The following is a description of a gene set: studied in species Homo sapiens Asymmetric growth A growth pattern that displays an abnormal difference between the left and the right side. Human Gene Set: HP_ASYMMETRIC_GROWTH, and this is the list of marker genes: HOXD13, GABRD, GNAQ, WT1 (NCBI Gene Id 7490), KCNAB2, PTH1R, ARL6IP6, BPTF, MNX1, GNA11, AKT1, ZNF699, H19, TRIP13, KCNQ1OT1, SPEN, FN1, DACT1, KRAS, PTHLH, IDH2, KAT6A, TRPV4, CASZ1, PLAG1, COL2A1, PTEN, EBP, TUBB, GRB10, MAPK1, AGGF1, ENPP1, PIK3CA, TONSL, SATB2, AKT2, CTSK, DMP1, SKI, EXT2, MMP23B, KCNQ1, PDPN, HNF1B, UBE4B, EFNB1, PRDM16, HSPG2, PRKCZ, ACTB, IDH1, LEMD3, MPV17, RERE, NRAS, MAPRE2, SETD5, TRIM28, BRCA2, RASA1, GPC3, IGF2, POU6F2, HMGA2, DNMT3A, RNF125, HRAS, EXT1, SALL1, IKBKG, USP9X, CDKN1C, PORCN, DIS3L2, LUZP1, REST, PSMD12